Given this list of marker genes SDHD (succinate dehydrogenase complex subunit D), PGM3, SDHA, RNU4-2, SOX9, HSD17B10, PLP1, ADNP, TMEM70, MADD, SDHB, PHGDH, AIFM1, MEG3, TBX4, KDM5B, NCAPD3, MAB21L1, IRX5, PSMC3, TPP2, TET2, RTL1, SDHAF1, HAL, NF1, TANGO2, CDKL5, DLK1, here is a description of the gene set: Human Gene Set: HP_MODERATE_GLOBAL_DEVELOPMENTAL_DELAY studied in species Homo sapiens A moderate delay in the achievement of motor or mental milestones in the domains of development of a child. Moderate global developmental delay